Given this list of marker genes Itgax, Stard13, Kdr, Cxcr4, Alox12, Csnk2b, Acvrl1, Ctnnb1, Foxp1, Ccm2, Adamts12, Rhoa, Rbpj, Bsg, Dll4, Rhob, Fgf1, Lcn2, Cxcl10 (NCBI Gene Id 15945), here is a description of the gene set: The process in which the anatomical structure of an endothelium is generated and organized. Endothelium refers to the layer of cells lining blood vessels, lymphatics, the heart, and serous cavities, and is derived from bone marrow or mesoderm. Corneal endothelium is a special case, derived from neural crest cells. Mouse Gene Set: GOBP_MORPHOGENESIS_OF_AN_ENDOTHELIUM species: Mus musculus